Given this list of marker genes Acss2, Echs1, Acsl5, Echdc1, Acaa2, Acly, Fasn, Decr1, Hadh, Acsl4, Acsl1, Acacb, Pcx, Pecr, Acsl3, Scd1, Echdc3, Acaca, Acsl6, Mecr, Echdc2, Ech1, here is a description of the gene set: species: Mus musculus Mouse Gene Set: WP_FATTY_ACID_BIOSYNTHESIS Fatty acid biosynthesis